The following is a description of a gene set: Any process that results in a change in state or activity of a cell or an organism (in terms of movement, secretion, enzyme production, gene expression, etc.) as a result of a peptide stimulus. studied in species Homo sapiens Human Gene Set: GOBP_RESPONSE_TO_PEPTIDE, and this is the list of marker genes: AKAP12, PDCD10, LRCH1, MIR26A1, MYB, SH2B2, RIPOR2, FOXF1, AFF3, SIRT1, NKX3-1 (NCBI Gene Id 4824), SCGB1A1, TOLLIP, IL17A, CXCL6, NLRP12, RIF1, MIR342, MIR34A (microRNA 34a), KRT8 (keratin 8), EFHC2, FCER1G, IL17F, TNFSF18, PIM1, MMP2, USP29, CDC34, IFNA5, VAMP4, CCR7, IL2RA, KLF15, VIM, FLNB, IL1R2, RFX2, MMP8, TANK, KDM5B, RPS6KA5, CRK, TNFRSF11A, DAPK1, WDR35, CALM1, MSC, IL17RE, MAPKAPK2, KAT2A, NOS2, ARHGEF2, DOK1, PPARG, CHUK, CRHBP, EPS8, RIPK1, CRLF1, GBP2, CRNN, PML, SIGIRR (single Ig and TIR domain containing), MIR433, EPO, LEF1, MIR181B1, OAS1, STAT3, ALAD, IL4, ACTN4, KMO, SLC25A5, EIF5A, FER, MIR135A1, RIGI, CXCR4 (C-X-C motif chemokine receptor 4), SRSF1, DOCK8, CCR6, MIR224 (microRNA 224), PDE12, IL1RL2, TNFRSF19, TRAF3 (TNF receptor associated factor 3), CXCL12, PRKN, SMAD7, EDN2, LAPTM5, GIPC1, MIR130A, CCRL2, SBNO2, TNFRSF18, GFI1, FCAR, LGALS9, CDC37, IL34, KLF4, RUFY4, NUP35, HCLS1, SNRNP70, TRAF1, CITED1, AGPAT2, LOX, TIMP1, PLSCR1, PCK2, IFNA2, MIR27B, NSMAF, IL23R, ABCG4, ST18, ATP5PO, HAX1, HIF1A, SRC, OTULIN, INPP5K, ADAM17 (ADAM metallopeptidase domain 17), CYBA, IL10, TRIM56, LIMS1 (NCBI Gene Id 3987), CFL1, YTHDF2, PTK2B, CIB1, SMAD4, ARG1, IL12B, IL18BP, GCLC, LILRB4, IL1B, PRL, PDE1B (phosphodiesterase 1B), BCL2L1, RBM47, MAP2K7 (NCBI Gene Id 5609), KRT18, ADIPOQ, WNK1, LAMP3, ALPL, HPX, SHMT1, SOS1, CDC42EP4, PPP1R9B, POLR1F, DPYSL3, LILRA5, CEACAM1, GPR146, NKX6-1, IL36G, MAPK3, HDAC4, TAX1BP1, CTSG, PLCB1, TNFRSF13C, PAX6, MYD88, GSTP1, ACOD1, ISG15, MIR204, RARA, FAS, MIR21, RPL3, PADI2, CD4, NR5A2, IFNA8 (NCBI Gene Id 95818), YAP1, IL17RD, STAT5A, STAT2, TIFA, RPS6KB1, CD40, KEAP1, IRF1 (NCBI Gene Id 96501), ZBP1, ADIPOR1, HCN1, SHPK, CCL26, CACNB4, HIPK1, CEBPB, GPR35, BBS2, CCL8, GBP5, MIR98, MAPK7, NRDC, IL37, MAVS, HEATR9, IL5RA, CLDN1, ZC3H15, IL12RB2, ASAH1, XCL2, TREX1, SPI1, CCR2, CREBRF, CREB1, IRS1, ACTG1, MIR20B, CRKL, RAB20, LIFR, TRAIP, ALOX15, ABCB1, ZNF268, IL13RA1, BSPRY, IL1A, MAP3K5, KIF5B, ADAM10, PELI3, MIR493, PHC1, USP18, GPS2, ENTREP1, CORO1A, TRIM63, IL15, NKIRAS1, SLIT3, BCL2, NLRC5 (NCBI Gene Id 84166), TIMP3, ADAR, PIK3R1, XRCC5, IRGM, JAK3, KRAS, IL2RG, IL12RB1, FOXO3, FBXO21, PYHIN1, LILRA2, SPHK1, CNOT7, IFNGR2, IL1RAPL2, IFNA7, CNTFR, EDA2R, ZFP36L1, MRPL15 (mitochondrial ribosomal protein L15), IRAK2, SLC30A8, TNIP2, MIR27A, TBK1, ACKR2, VRK2, TLR2, ACTR2, MIR152, GAS6, IFNA1, RHOA, TNFRSF21, IL1RAP, H2BC11, IL27RA, UPF1, DAB2IP, IFNL1, EGR1, MME, CALR, ST3GAL6, GATA3, VCAM1, GFPT2, CCR1, CYLD, FOXP1, UMOD, HSPA1B, KLF5, HES1, IL18RAP, EDN1, NFAT5, BGLAP, MT3, MNDA, CXCR2, BIRC7, KDM3A, C1QTNF4, ZYX, BIRC3, PRKACA, CD38, CDC42, IFNW1, TNFRSF1A, HSF1, CASP1, CASP4, PRLR, FOXC1 (NCBI Gene Id 3666), EIF4E2, LSP1, TLR3, CDK9, IL3RA, CBL, MIR138-1, TCIRG1, TFF2, OSMR, PYDC2 (NCBI Gene Id 285305), SPATA2, COMT, BMI1, EEF1E1, SLC2A4, NR2C2, APPL2, ANO1, FLT3, IL4R, LCN10, CXCL16, XBP1, NR1H3, NME7, GBP6, ADAM9, EDA, PFKP, AVPR2 (arginine vasopressin receptor 2), ASAH2, IL15RA, THPO, DICER1, STX4, ITGA4, KLF1, NUMBL, IL5, MIR101-1, IL9R, NUB1, AZI2, STXBP3, COL1A1, NFE2L2, SOX17, THBS1, CCL19, GPER1, ENDOG, MIR520C, MCF2, PTPN1, IL6R, CCR4, MMP12, SOX1, EPG5, SLC11A1, JAK1, SYNGR1, TREM2, AIM2, IL16, SETD2, GBP4, TYK2, OASL, APPL1, MX2, IFNA6, IL18R1, MAP3K7, RNF185, ICAM1, ACKR4, ACP5, GAPDH, RIPK2, OAS3, CD200, CYP27B1, CCR10, RPS3, POSTN, IFITM2, IFNA17, TICAM2, TEX14, CCL15, OAS2, PLVAP, CACYBP, LILRA3, METTL3, MAPK11, MIR99A, TBKBP1, IKBKB, MUL1, USP25, STAT1, CXCL8, HCK, GBP3, IFI27, PDGFB, SERPINA3, DTX1, CCR5, SOCS1, KCNJ8 (potassium inwardly rectifying channel subfamily J member 8), HK2, MT1X, SLC1A1, CACTIN, IFNA14, CPNE1, CR2, VAMP3, TTLL12, MIR29B1, CX3CL1, CCL4L2, EIF2AK2, GCH1, IFNA16, STING1, GPR108, IL36A (interleukin 36 alpha), PTPN6, MIR31, IRF7, F2RL1, ALDH1A2, ECM1, LILRB3, ADIPOR2, MAT2A, IFI16, ARID5B, NLRP2B, MAPK1, ACTR3, CCL23, FOXA2, GPR17, CASR, GCLM, MIR146A, TCF7, SFRP1, CCL2, IL11RA, PTGIS, HTRA2, IL1F10, ACSL1, UBE2K, PDIA3, JAK2, IFNGR1, ZFAND6, MX1, ZFP36L2, KLF2, HYAL1, WBP1L, TMSB4X, NR1H4, PXDN, DCSTAMP, NFKBIA, RRAGA, ABCD4, SPPL2A, IL17RA, TAF9, RABGEF1, ACKR3, IL20RA, LILRA1, CCR8, SELPLG, AKAP6, RIPOR1, IL21R, MIR766, IL7, CSF2RA, TSLP, ANXA4, IFNL4, TXNDC17, IL9, SPPL2B, SLC34A1, TIMP2, INA, EPOR, UBD, CSF2RB, CALCA, NOL3 (nucleolar protein 3), ERBIN, PTPRT, FASN, ZNF675, CSNK2B, RBMX, CCL21, FOS, RORA, KHSRP, FOSL1, STX8 (syntaxin 8), CCL25, FZD4, IFITM3, SRSF7, SOCS2, IRAK1, MAP2K5, YBX1, ANGPT1 (NCBI Gene Id 284), STXBP4, TRAF5, IRF5, LEP, CLCF1, LRP8, SELE, TMC8, MYBL2, MYO1C, OTOP1, NLRP6, TLE4, PTP4A3, ADAMTS13, RO60, STAT6, SPRY2, ASS1, CDC42EP2, MED1, SOCS4, NFYB, REL, CARD8, ATIC, LRRC70, IL10RA, IL24 (NCBI Gene Id 11009), IFNK, WNT5A, XCR1, YTHDC2, YY1, TUBA1B, AIF1, PRKCI, SAMHD1, RPL13A, LILRA6, PPP3CB, MCL1, IL36RN, AANAT, IL1R1, IL1RL1 (NCBI Gene Id 9173), CLDN18, KIT, MIR149, TP53 (tumor protein p53), MIRLET7A1, TUBA1A, DCST1, BCLAF1, LYN, IL1RN, DDOST, XCL1, MIR20A, TPR, TNFRSF4, CD74 (NCBI Gene Id 972), DUOX2, PF4, RFFL, CCL14, IRF8, GSK3B, CCL7, MIR133A1, TRIM44, CD58, BCAT2 (branched chain amino acid transaminase 2), FGF4 (fibroblast growth factor 4), MIR30C2, TFRC, CTH, CD274 (CD274 molecule), TNFRSF1B, SELP, IFNL2, IFIT1, IL13, SEC61A1, FABP4, CCL13, TNFRSF25, AKT1, MIR455, COL6A1, CCL16, VEGFC, MEFV, HYAL3, TNFSF11, RAD23B, EREG, MIR370, CXCL11, OXSR1, CX3CR1, SKIL, SRSF3, CCL3L3, MIR24-1, FASLG, CXCL9, RPS16 (ribosomal protein S16), IL12A, MYLK3, CDK5R1, RARG, BTK, SNCA, IL17RC, KLF3, PID1, CMKLR1, NAIP, CRIPTO, TRIM41, GH1, SPOCK2, STK39, LILRB1, IFNA10, IFITM1, CCDC3, PARP9, GIGYF2, NCL, PARP16, IFNA4 (NCBI Gene Id 8006), GPD1, PTPRJ, IL7R, CALCOCO2, KYNU, MAP4K3, SLC26A6, YTHDF3, CCL11 (C-C motif chemokine ligand 11), BIRC2, ILK (NCBI Gene Id 55522), SLC22A5, IL6, CAMP, XAF1, ADAMTS7, TNFRSF11B (TNF receptor superfamily member 11b), MYOG, WAS, IL10RB, PARP14, FCHSD1, NRP2, CCL5, STAP1, SYK, IKBKE, SIN3A, HSP90AB1, CIITA, MIR142, RELA, NFKB2, OSM, IFNA21, NPR2, HSPD1, HYAL2, CCL22, CAPN2, MIB2, NOTCH1, CSF3R, DUSP1, IFIH1, NDUFA13, P4HB, MRC1 (NCBI Gene Id 4360), CHI3L1, PNPT1, AGPAT1, CCR3, IMPDH2, COL3A1, MAPKAPK3, PYCARD, UBXN2A (NCBI Gene Id 165324), CCL1, MAPK13, SLC27A1, PTPN2, AXL, IL13RA2, IL2RB, CD300LF (CD300 molecule like family member f), FIS1, STXBP1, CXCL13, TMEM102, HMHB1, TRIM25, CASP3, DNAJA3, SMPD3, UBE2G2, HSPA1A, SNX10, SOCS5, KLF11, EIF4A2, ETV3, P3R3URF, GSN, ABCA1, EED, CSF3, RHEX, TNF, IL17REL, MCM2, USP10, DUOX1 (NCBI Gene Id 53905), CCL3, STAT4, NEFH, SMPD1, OTUD4, XIAP, CEBPA, CAMK2A, NMNAT3, CD24, MPL, PRDM5, SLIT2, FOSL2, RNF138, TRIM21, IL31RA, MKKS, IFNL3, NLRP7, SRM, SPRY4, PIAS3, PHB1, ANKRD1, NFIL3, CDK4, YBX3, CCL18, PTPN11, ZC3H12A, SIRPA, IL22RA1 (NCBI Gene Id 58985), GSK3A, MIR1246, ILDR1, POU4F1, SH2B3, CRLF2, ADAM23, IL11, IFNLR1, IFNG, SSTR1, IFNB1, FADD, RNMT, SRF, IL17RB, USP27X, CASP8, BBS4, FGF23, IL33, SHARPIN, EDAR, F3, CXCR3, RAB7B, LILRB5, PDX1, CXCR5, RAF1, GLDC, LCN2, TNFRSF17, PMM1, NFKB1, SHFL, GBA1 (glucosylceramidase beta 1), CXCL10, MYOD1, COMMD7, TRIM2, TLE5, CD47, LRAT, GREM2, IRS2, MTF2, RAB43, NKIRAS2, GNPNAT1, CD70, CSF1R, INHBA, IFNE, PALM3, EPRS1, SMPD4, ITIH4, TNFSF13B, HAS2, TRAF3IP2, RNF113A, STAT5B, TRAF6, RPS6KA4, IFNAR2, PIGA, ZNF697, LDLRAP1, SPP1, LILRB2, RC3H1, PLA2G10, IL22RA2, CNTF, ACKR1, PCOLCE2, SMARCA5, DAPK3, MYC, CH25H, CARD14, NFKBIZ, MIRLET7C (NCBI Gene Id 406885), UGCG (UDP-glucose ceramide glucosyltransferase), B3GNT2 (UDP-GlcNAc:betaGal beta-1,3-N-acetylglucosaminyltransferase 2), SHMT2, STXBP2, CXCR6, IL20RB, ADAMTS12, BAD, BAG4, NPNT, GHR, IGBP1, CSF1, CISH, FOXH1, PAFAH1B1, PYDC1, PDE2A, SERPINF1, HNRNPU, MST1R, CTR9, BRCA1, IL36B, VPS26B, ABCC9, MIR125A (microRNA 125a), JAGN1, PRKCA, SLC12A2, PPP2CB, BST2, MRAS, HMGB1 (NCBI Gene Id 3146, high mobility group box 1), IRAK3, APOA1, POU4F2, CAV1, CCL24, AQP4, SYNCRIP, MIRLET7E, ULK1, PIAS4, PRPF8, MAPK14, TLR4, TNFRSF14, PLP2, IRAK4, CSF2, MIR125B1 (NCBI Gene Id 406911), IL6ST, STIP1, EBI3, IFNAR1, JARID2, MIR324, NR1D1, CXCR1, SOX9, INHBB, IL3, TXK, APP, TRIM6, TRAF2, GBP7, TRIM32 (tripartite motif containing 32), SP100, LILRA4, ZFP36, RNF125, TRIM65, FGB, CCL4, RELB, CNOT9, LEPR, HELLS, LSM14A, SELL, NR1H2, HLA-DPA1, KLHL20, OCSTAMP, DHX9, ATP5F1B, CARD16, IL2, GSDME (NCBI Gene Id 1687), TRADD, GPR75, IL18, HSPA5 (NCBI Gene Id 3309), TIMP4 (NCBI Gene Id 7079), CD44, MT2A, SOCS3, PYDC5, CCR9, RBM15, ROBO1, PTPRC, GBP1, DDX41, TNFAIP3, SMIM30, MTHFR, MYNN, EXT1, IRF3